The following is a description of a gene set: Combining with the biogenic amine serotonin and transmitting the signal across the membrane by activating an associated G-protein. Serotonin (5-hydroxytryptamine) is a neurotransmitter and hormone found in vertebrates and invertebrates. studied in species Homo sapiens Human Gene Set: GOMF_G_PROTEIN_COUPLED_SEROTONIN_RECEPTOR_ACTIVITY, and this is the list of marker genes: HTR2C, HTR1D, DRD4, HTR1E, HTR2A, HTR1B, HTR6, HTR2B, HTR1A, HTR1F, HTR7, HTR4, HTR5A (5-hydroxytryptamine receptor 5A)